Given this list of marker genes Junb, Tmsb10, Rgs1, Emb, Jun, Fos, Jund, Fosb, Il7r, here is a description of the gene set: Cytokines mediate cell-cell communication in the immune system and represent important therapeutic targets. A myriad of studies have highlighted their central role in immune function, yet we lack a global view of the cellular responses of each immune cell type to each cytokine. To address this gap, the authors created the Immune Dictionary, a compendium of single-cell transcriptomic profiles of more than 17 immune cell types in response to each of 86 cytokines (>1,400 cytokine-cell type combinations) in mouse lymph nodes in vivo. A cytokine-centric view of the dictionary revealed that most cytokines induce highly cell-type-specific responses. For example, the inflammatory cytokine interleukin-1β induces distinct gene programmes in almost every cell type. A cell-type-centric view of the dictionary identified more than 66 cytokine-driven cellular polarization states across immune cell types, including previously uncharacterized states such as an interleukin-18-induced polyfunctional natural killer cell state. Genes negatively differentially expressed in cell type: NK cell upon treatment with cytokine: APRIL in mouse lymph nodes in vivo. Mouse Gene Set: CUI_NK_CELL_APRIL_RESPONSE_DN studied in species Mus musculus from publication Cui A, Huang T, Li S, Ma A, Pérez JL, Sander C, Keskin DB, Wu CJ, Fraenkel E, Hacohen N (PMID 38057668)